The following is a description of a gene set: Enables the energy-independent facilitated diffusion of a potassium ion through a transmembrane aqueous pore or channel. Human Gene Set: GOMF_POTASSIUM_CHANNEL_ACTIVITY studied in species Homo sapiens, and this is the list of marker genes: HCN3, KCNMB1, LRRC26, GRIK4, KCNC1, KCNJ14 (NCBI Gene Id 3770), KCNE2, KCNJ10, KCNH3, DPP6, AKT1, GRIK3, TMEM175, GRIK5, KCNIP1, KCNJ2, KCNK15, WWP2, KCNH8, KCNK18, ABCC8, KCNV2, KCNK6, KCNJ9, KCNIP4, AMIGO1, KCNE4, KCNV1, KCNJ4, KCNH4, KCNJ15, YWHAE, KCNG3, DRD2 (NCBI Gene Id 91906), KCNA4, KCNC4, KCNQ1, KCNIP2, KCNK7, KCNA6, DPP10, KCNQ4, P2RX7, CHP1, STK39, HCN2, KCNQ2, CAV3, HCN1, ADRB2, LRRC52, KCNT1, KCNK5 (NCBI Gene Id 8645), KCNC3, SGK3 (serum/glucocorticoid regulated kinase family member 3), TMEM87A, ANK2, KCNE3, KCNAB3, SGK1, AKAP9, CAV1, SLC5A3, KCNN2, KCNMB2, HCN4, SNAP25, KCNA5, KCNH1, NEDD4, KCNN3, KCNB1, ABCC9, KCNK4, KCNE5, KCNS2, C8orf44-SGK3, CCT8L2, TMEM38A, KCNC2, TRPM5, SGK2, KCNK3, NEDD4L, KCNH5, KCNAB1, KCND1, KCNJ13, KCNN4, DLG1, GRIK1, KCNA7, KCNMB3, KCNAB2, KCNS1, KCNA2, DRD4, KCNQ3, KCNN1, KCNH2, KCNB2, KCNJ18, SCN2B, ARPP19, KCNJ11, KCND3, LRRC38, AQP1, OXSR1, CCDC51, KCNS3, KCNMB4, KCNT2, KCNK9, KCNQ5, KCNJ3, KCNF1, KCNK12, KCNIP3, KCNK2, GRIK2, KCNJ12, KCNK16, FLNA, PKD2L1, KCNH7, KCNJ16, SUMO1, KCNMA1, KCNJ8, PKD2, ENSA, KCNK13, TMEM38B (transmembrane protein 38B), KCNK10, RASA1, KCNK1, KCNU1, MCOLN3, KCNJ5, KCNH6, FHL1, KCNA1, KCNJ1, KCNA10, KCNG2, LRRC55, MCOLN1, KCNK17, KCNG4 (potassium voltage-gated channel modifier subfamily G member 4), KCND2, KCNG1, KCNJ6, KCNA3, KCNE1